The following is a description of a gene set: Wrinkled, redundant, inelastic and sagging skin. Cutis laxa Human Gene Set: HP_CUTIS_LAXA species: Homo sapiens, and this is the list of marker genes: COL3A1, CHST3, EFEMP2, MRAS, FLNA, ATP6V1E1, RAD21, SLC7A7, STX1A, GTF2I, FKBP14 (NCBI Gene Id 55033), FBLN5, H1-4, ALG12, MRPS16, CD96, CSPP1 (NCBI Gene Id 79848), PTEN, ATP6AP1, ADAMTS2, TBX15 (NCBI Gene Id 6913), SEPTIN9, CHST14, PRMT7, GSN, METTL27, RPS6KA3, MAP2K1 (NCBI Gene Id 5604), WDR37, BAZ1B, NPR2, ALDH18A1, GTF2IRD2, MRPS22, RIN2, EIF4H, XYLT1, EZH2, B3GAT3, SUZ12, ASXL1, LTBP4, MAN1B1, B4GALT7, FGFR2, EBP, EXT1, GTF2IRD1, ATP6V1A, CDK13, FGFR3, ATP6V0A2, FBN1, B4GALT1, LTBP1, NSD1, TGFB2, C1R, DNAJC30, ATP6AP2, KRAS, AEBP1, LIMK1, SLC6A8, SRD5A3, MEG3, NAA10, PEX1, TBL2, WDR81, TRAF7, MLXIPL, NDUFB11, IFT43, RIT1, FKBP6, PITX2, ALG8, TRPS1, ABCC6, FIG4, ATP7A, MAP2K2, SLC2A10, GPX4, IPO8, HRAS, SLC25A24, NCF1, WDR35 (WD repeat domain 35), PLOD1, ELN, CLIP2, NDUFB10, FGF20, SPINT2, ENPP1, VAC14, AARS1, DLK1, DSE, IFT140, GGCX, GNB2, HPGD, PTDSS1, KIAA0586, FOXC1, VPS37D, CEP55, WDR19, ZNF469, PIGA, NBAS, TMEM270, EFEMP1, MEGF8, XYLT2, GORAB, RTL1, BCL11B, B3GALT6 (NCBI Gene Id 126792), RFC2, LZTR1, BUD23, PYCR1, ANTXR1, OTUD5, NEPRO, TWIST2, SH3PXD2B, BRAF